Given this list of marker genes Pex26, Pex3, Pex16 (NCBI Gene Id 228367), Pex19, Pex5, Rab8b, here is a description of the gene set: The targeting of proteins into the peroxisomal membrane. The process is not well understood, but both signals and mechanism differ from those involved in peroxisomal matrix protein import. studied in species Mus musculus Mouse Gene Set: GOBP_PROTEIN_IMPORT_INTO_PEROXISOME_MEMBRANE